Given this list of marker genes KYAT3, RBM33, FBXL12 (NCBI Gene Id 54850), CRIPTO, ACVR2A, ZMYM5 (NCBI Gene Id 9205), PDE12, ZDHHC23, POU5F2, TBC1D19, FAM156A, RO60, SLC20A1, DNM3OS, RNF14, CPPED1, ZC3H12D, TFB2M, SLC18A2, SPATC1, ZNF512B, HDAC8, ITPR2, USP24, CHMP3, TMEM87B, GREB1, SLC4A5, NDRG1, SMYD3, KIF16B, MBNL1, PKD1, SZT2, CIR1, EXOC6B (NCBI Gene Id 23233), POFUT1, CST3, GOLM2, PAOX, ZC2HC1C, FYCO1, GK5, SERPINI1 (NCBI Gene Id 5274), LCA5, FAM120B, SYNJ1, H1-2, ARHGAP12, MXRA8, SV2A, C19orf38, IFT88, SLC37A1, ESM1, ATP8A1, PRKAB2, CRNKL1, PHACTR2, NOTCH1, CREBL2, CRAT, PLEKHA8, LRGUK, BMPR1A, PLA2G4F, FUT10, PDE1A, CTNNA1, PDIA2, F9, APPL1, IPO11, CEP76, DST, RALGAPB, CDC42BPB, ATXN1L, MTX3, SIDT1, MTREX, KCNIP4, TNKS2, WDR13, PGRMC2, ATP6V0E2, CYBRD1, TKTL1, DPP4, AHI1, CXCR2, UTRN, GOPC, CYP39A1, IL18R1, FATE1, ADGRB3, CYP2E1, DDHD2, SNX16, MBLAC1, CPNE4, ZAN, NUB1, ARID5B, SNX14, DYNC1H1, MIR421, SLC4A1AP, RICTOR, RWDD3, MAPK10, SLC10A2, INSIG2, TMSB10, STAU2, CERS6, TTC28, TCEAL1, RETSAT, CD302, MAPK12, ZFP1, NFE2, SLAMF6, ZFYVE26, EHMT2, RSBN1, CTSL, ALDH5A1, IL18BP, OLFML3, ARL13A, AKAP11, TMEM183A, ANKS4B, SCG5, CMAHP, MPP7 (MAGUK p55 scaffold protein 7), RANBP9, FRMPD4, SCPEP1, IL23R, GTPBP6, PON3, here is a description of the gene set: studied in species Homo sapiens from publication Yarilina A, Park-Min KH, Antoniv T, Hu X, Ivashkiv LB (PMID 18345002) Genes down-regulated in macrophages from patients with synovial fluid rheumatoid arthritis versus monocyte-derived macrophages from healthy persons. Macrophages from RA synovial fluids were compared to primary human blood-derived macrophages. Human Gene Set: GSE10500_ARTHRITIC_SYNOVIAL_FLUID_VS_HEALTHY_MACROPHAGE_DN